The following is a description of a gene set: The portion of the plasma membrane surrounding a lamellipodium. Mouse Gene Set: GOCC_LAMELLIPODIUM_MEMBRANE studied in species Mus musculus, and this is the list of marker genes: Vasp, Dpp4 (dipeptidylpeptidase 4), Fap, Apc2, Nckap1, Itgb3, Piezo1, Syne2, Pdpn, Plek2, Cdc42, Cspg4, Plxnd1, Kcna2, Cd44, Pdxp, Cfl1, Slc39a6, Fermt2, Dock8, Antxr1, Itgav, Epha2